The following is a description of a gene set: Genes up-regulated in MEF cells (embryonic fibroblast) isolated from NRAS knockout mice. We characterized differential gene expression profiles of fibroblast cell lines harboring single or double-homozygous null mutations in H-ras and N-ras. Whereas the expression level of the individual H-, N- and K-ras genes appeared unaffected by the presence or absence of the other ras loci, significant differences were observed between the expression profiles of cells missing N-ras and/or H-ras. Absence of N-ras produced much stronger effects than absence of H-ras over the profile of the cellular transcriptome. N-ras(-/-) and H-ras(-/-) fibroblasts displayed rather antagonistic expression profiles and the transcriptome of H-ras(-/-) cells was significantly closer to that of wild-type fibroblasts than to that of N-ras(-/-) cells. Classifying all differentially expressed genes into functional categories suggested specific roles for H-Ras and N-Ras. It was particularly striking in N-ras(-/-) cells the upregulation of a remarkable number of immunity-related genes, as well as of several loci involved in apoptosis. Reverse-phase protein array assays demonstrated in the same N-ras(-/-) cells the overexpression and nuclear migration of tyrosine phosphorylated signal transducer and activator of transcription 1 (Stat1) which was concomitant with transcriptional activation mediated by interferon-stimulated response elements. Significantly enhanced numbers of apoptotic cells were also detected in cultures of N-ras(-/-) cells. Our data support the notion that different Ras isoforms play functionally distinct cellular roles and indicate that N-Ras is significantly involved in immune modulation/host defense and apoptotic responses. Mouse Gene Set: CASTELLANO_NRAS_TARGETS_UP from publication Castellano E, De Las Rivas J, Guerrero C, Santos E (PMID 16909116) species: Mus musculus, and this is the list of marker genes: Dlx5, Trim11, Crybg1, Kctd12, Vnn1, Sardh, Pcbd2, Clec11a, Tap1, Gm33887, Il13ra1, Pon3, H2-D1, Pltp, Tmem43, Ccng1, Nqo1, Iigp1, Slc66a3, Ifi203, Yif1a, Acadm, B2m, Lcn2, Isg15, Crabp2, Psmb8, Anxa8, Mmp13, Stat1, Mgp, Ephx1, H2-K2, Ifi27l2a, Gja1, Itih2, Tulp4, Ifi204, Crip2 (cysteine rich protein 2), Irgm1, Zfp637, Ifi202b, Bax, Ercc5, Ak1, Cx3cl1, Lbp, U90926, Il1rn, Tubb2a, Scx, Adcy2, Nsg1, Cfh (complement component factor h), Plscr2, Ugt1a2, Ifit1 (interferon-induced protein with tetratricopeptide repeats 1), Perp, Exoc4, Penk, Npr3, Ptx3, Enpep, Ifih1, Usp18, Vps25, Tgtp1, Fndc3a, Serpine2, Arxes2, Ppp1r7, Zfp703, Ifi35, Gbp2, Anxa4, P3h4, Phlda3, Lsp1, Mest, Sdc1, H2-Q5